Given this list of marker genes WDFY3-AS2, PKP1, ERICH3, SMR3B, RDH12, CEACAM19, OSTM1-AS1, KIR2DS5, MEPE, PCDHGC5, ONECUT2, ADSS1, OR7E104P, ERG, RHOJ, IQSEC2, SLC22A12, NR2F2-AS1 (NCBI Gene Id 650193), NPAS3 (NCBI Gene Id 64067), ECM1, USB1, HSPB7, FOSL2-AS1, MMD2, PNLDC1, CROCCP3, ITGAD, ACSBG1, CADM4, MIR3150BHG, FMO2, C2orf92, MC5R, CDX2, HEMGN, ST6GALNAC5, FOLR2, DTX4, FGL2, PRSS33, HPSE2, ELOA3P, PI3, CCK, CHI3L2, SRRM5, ENSG00000235143, DSC1, GRK5, CIB2, PDE7B-AS1, LINC02724, BMP5, TEX46, SOX14, KRTAP4-8, ADCY8, SMIM29, RNF207, MAGEA5P, BAHCC1, CASP4LP, WIPF1, FSD2, CYSLTR1, MYRF-AS1, PTTG2, ZNF710, ACSL6, CASP4, OR2C1, CLEC4F, KCNS1, TARP, UNC5A, PCARE (photoreceptor cilium actin regulator), B4GALT4, NXPE4, ZNF497, TMPRSS13, HDAC10, IRF5, AACSP1, LY6G6C (NCBI Gene Id 80740), ABCA8, ENG, ADAMTS9, TINAGL1 (tubulointerstitial nephritis antigen like 1, NCBI Gene Id 64129), WFDC9, NAV2-AS4, NEDD9, NRXN1, BICDL2, CCDC9, CLEC14A, LINC01148, SHROOM1, KRT14, TACR2, CALHM4, SLC16A7, HDAC11, ZBED3-AS1, SYT13, AFF2, XYLB, ENSG00000291228, KCNA1, CHST4, LRRC8C-DT, SNAI3-AS1, CRISP3, GNA15, SPATA31E1, DYDC2, WNT2B, PRO1804, WNT1, UNC13C, ABCB11, SERPINB9, IL10RB-DT, ANO7L1, MATN1 (NCBI Gene Id 4146), CLDN4, CCDC154, OR1A2, MUC19, SPRR2C, SSTR3, FRMPD1, LINC01056, TPPP2, VPREB3, NCKAP5L, NEU4, DNAH12, RAET1E, VWA1, LINC00334 (long intergenic non-protein coding RNA 334), ODAD1, XCR1 (NCBI Gene Id 2829), ZNF488 (NCBI Gene Id 118738), CYP27C1, SPAG5-AS1, FCRL2, MSMB, LINC01120, TMEM176A, AARS1 (NCBI Gene Id 16), PPP4R1L, WDR93, TTLL9, IL11, HAS2, TRIM16L, CRISPLD2, HCP5B, EIF4EBP1, CPT1C, OR1A1, STPG1, KLRB1, TEX11, ADCY2, CD247, CLDN20, ZNF671, FCHO1, KCTD21, S1PR3, CD99P1, TMEM52B (NCBI Gene Id 120939), LINC00664, FBXL19, CTSF, SPP1, IHH, ZNF641, TCP11L1, CCDC115, BTBD10, IL5RA, NLRC4, TP73, KIF6, KRT82, FBXO36, PLA1A (phospholipase A1 member A), OR52A1, LRRC37A2, here is a description of the gene set: Human Gene Set: GSE37336_LY6C_POS_VS_NEG_NAIVE_CD4_TCELL_DN Genes down-regulated naïve CD4 T cells: Ly6c+ versus Ly6c-. species: Homo sapiens The naive CD4 T cell compartment is heterogeneous. Ly-6C- and Ly-6C+ Naive CD4 T cells were compare by microarrays.